Given this list of marker genes APRT, BLOC1S6, UPP1, TK1, PGM2 (phosphoglucomutase 2), ADA, ACP3, DCTD (NCBI Gene Id 1635), GNMT, CDA, AICDA, MACROD1, DGUOK, PNP, UCKL1, UPB1, MAPDA, MACROD2, TK2, DNPH1, CDADC1, DTYMK, DHFR2, TYMP, NT5C1B, UPP2, ENPP4, ADA2, ADK, ICMT, NT5C3A, QNG1 (Q-nucleotide N-glycosylase 1), PRTFDC1, DPYD (dihydropyrimidine dehydrogenase), APOBEC3C, GDA, NME4, APOBEC3G, NT5C1A, OARD1, XDH, ERH, NT5E, NT5C2, NME5, NUDT1, DERA, PTGDR, HPRT1, MTAP, here is a description of the gene set: studied in species Homo sapiens The chemical reactions and pathways involving a nucleoside, a nucleobase linked to either beta-D-ribofuranose (a ribonucleoside) or 2-deoxy-beta-D-ribofuranose, (a deoxyribonucleoside), e.g. adenosine, guanosine, inosine, cytidine, uridine and deoxyadenosine, deoxyguanosine, deoxycytidine and thymidine (= deoxythymidine). Human Gene Set: GOBP_NUCLEOSIDE_METABOLIC_PROCESS